Given this list of marker genes GGH, GRN, ARG1, TUBB4B, BPI, GLA, CCT2, C6orf120, GM2A, FUCA1, ADA2 (NCBI Gene Id 51816), CCT8, NHLRC3 (NHL repeat containing 3), PA2G4, MAN2B1, PADI2, STK11IP, NAPRT, TRAPPC1 (trafficking protein particle complex subunit 1), PTGES2, DPP7, ELANE, HEXB, DEFA1, GCA (grancalcin), PRSS57, CPPED1, UNC13D, SERPINA3, VAT1, ARSB, HEBP2 (heme binding protein 2), TOLLIP, DNAJC3, PRTN3, S100A7, CREG1, PYGB, DEFA1B, GUSB, PRDX6, ARHGAP45, DYNC1H1, HRNR, PRSS2, RNASET2, CTSC, FUCA2, GLB1, RETN, PRKCD, NPC2, ORM2, PYCARD, SERPINB3, ARSA, FABP5, ACTR2, GNS, AZU1, ACTR10, SDCBP, RNASE2, FTL, PSMD1, IMPDH1, ANXA2, TXNDC5, CYB5R3, ACLY, DSN1, GDI2, TUBB, FAF2, MPO, PLAC8, DEFA3, FRK, MAPK1, CTSA, IST1, CAP1, RNASE3, GALNS, MNDA, AGA (aspartylglucosaminidase), LYZ, CTSG, VCP, C3, TTR, here is a description of the gene set: Human Gene Set: GOCC_AZUROPHIL_GRANULE_LUMEN The volume enclosed by the membrane of an azurophil granule, a primary lysosomal granule found in neutrophil granulocytes that contains a wide range of hydrolytic enzymes and is released into the extracellular fluid. studied in species Homo sapiens